Given this list of marker genes WSCD1, CHD1, SLC25A32, F2RL1, AK1 (NCBI Gene Id 203), BCL2L11, CRTAM, BEX1, RUFY2, GPATCH2, TLCD3A, PDCD11, PYGB, SNAPC2 (small nuclear RNA activating complex polypeptide 2), PPP2R3A (NCBI Gene Id 5523), GMFB, PPP1R37, RBMS2, ADAMTSL2, TMCO1, NAB1, FGD1, FAM114A1, SERPINB8, CBARP, ZNF706, DCBLD2, SCAND2P, GRAPL-AS1, MRPL39, PDGFA, TRIM25, ZNF432, RASA1, MMP20, ANKRD55, MAPK1IP1L, SGSM2, ADAMTS8, ACVR1B, TARP, CAV1, RPS27, TSC22D1, NNAT, LRRC8B, OTUD3, CXCL3, MAP2K3, IL6ST, DCSTAMP, CCND1, TCIM, ELMO3, UBQLN3 (NCBI Gene Id 50613), SNAP91, KMO, ATP2B1, ELOVL2, GLS, SPSB1, IRX4, RRP15, GPR171, ZC2HC1C, GFPT1, WDR45B, EIF1AY, SPMAP2, NTS, PHLDA2, SIK1, SHOX2, NPIPB3, VPS37A, KRT4, ZNF334, RAP1B, GNA15, PSG3, MSC, KCNK5, STAU2, RASAL1, MARCKS, RUNDC3B (RUN domain containing 3B), RRAD, MCL1 (NCBI Gene Id 4170), DOK5, ACVR1, RIN1, SH2B3, MPP1, CASS4, CD72, IFNGR2, PMCH, EGR4, ADAM29, LYPD1, AIM2, OTUD4 (NCBI Gene Id 95936), INPP1, PAH, TEKT2, BZW1, GNG4, PRNP, ARAP2, CAMK4, KCTD15, VLDLR, NDRG4, STK38L, INSL4, LYPD3 (NCBI Gene Id 94931), TRHDE, FGF7, PELI1, CSGALNACT2, MATK, NINJ1, BTG3, MYC, SLC7A10, PTPN7, ERF, PIK3C2B, GABBR1, CHGA, ATG4B, EID1, ENPP2, PPP2R2D, RASGRF1, MTRF1L, NIT1, ACTN2, HPCAL1, IRF4, MCTP2, DYRK3, NMBR, FBXO41, UNC93A, NXF1, DKK2, ASGR1, SLCO4C1, KCND2, CWF19L1, NUS1P3, GATA6, BBOF1, F13B, MAP7, CLDND1, ERO1B, SMOX, FOXA2, ZNF613, TENT4A, MTMR11, MAGEA1, MAT2A, SHCBP1L, MORC1, SOCS1, RCOR1, CD19, NDEL1, MAGT1, CD82, SCN11A, ABCG2, BAIAP2, CYP1A2, PER2, EHD2, FRS2, EIF2AK3, TMC6, ME1, SDS, CD200, TNFAIP1, ARC, SOCS2 (NCBI Gene Id 8835), BTBD7, STK19, BRAF, KLF4, PIGL, NABP1, MMP16, TNFRSF12A, here is a description of the gene set: Genes up-regulated in the in vitro follicular dendritic cells from peripheral lymph nodes (96h): tretinoin versus tretinoin and Pam2CSK4. Germinal centers (GCs) are clusters of activated B cells built on stromal cells known as follicular dendritic cells (FDCs). In the Peyer’s patches (PPs), GCs are chronically induced by bacteria and are the major sites for generation of gut IgA immune responses. Whether FDCs directly contribute to the IgA production in PP GCs is unknown. To investigate the role FDCs in gut immune system, we examined comprehensive gene profiles of FDCs purified from PPs or perypheral lymph nodes (pLNs) with or without immunization. We also tried to reconstitute the PP FDC signature in vitro by pulsed or continuous stimulation of pLN FDCs through TLRs, RARs or simultaneously through TLRs and RARs. Human Gene Set: GSE19401_RETINOIC_ACID_VS_RETINOIC_ACID_AND_PAM2CSK4_STIM_FOLLICULAR_DC_UP species: Homo sapiens from publication Suzuki K, Maruya M, Kawamoto S, Sitnik K, Kitamura H, Agace WW, Fagarasan S (PMID 20643338)